The following is a description of a gene set: from publication Yevshin I, Sharipov R, Kolmykov S, Kondrakhin Y, Kolpakov F (PMID 30445619) species: Mus musculus Mouse Gene Set: ARID4B_TARGET_GENES, and this is the list of marker genes: Trit1, Kdm4d (NCBI Gene Id 244694), Tmsb10, Mfsd11, Armc7, Vac14, Emc8, Eno3, Pard3b, Mettl3 (methyltransferase 3, N6-adenosine-methyltransferase complex catalytic subunit), Tbl1xr1 (transducin (beta)-like 1X-linked receptor 1), Smoc1, Rpl3, Tlk2 (NCBI Gene Id 71049), Cdk12, Wdr53, Vamp2, Mrpl14, Nln, Stk11, C2, Fbxo21, Resf1, Nup35, Dpm1, Rab10os, Gm36527, Eif2b3, Enkd1, Zfp799, Rpl5, Nufip2, Dusp1, Fbxl7, Gm20716, Spata6, Ints7, Hivep1, Vps37a, Dhrs1, Pnpla7, Epc1, Tbcc, Zgrf1, Rpl35a (ribosomal protein L35A), Selenos, Cisd3, Zfp839, 1810012K16Rik, H2ac5-ps, Mafa, Plec, Gkap1, Stx18, Tcf7l2, Spcs3, Tmem64, Eif3j1 (NCBI Gene Id 98779), Mrpl13, Ywhae, Cbfa2t2, Galnt16, Tsr1, Coq8a, Raly, Cacng2, Ets2, Nhlrc3, A430018G15Rik, Adk, Gm29417, Gpx4, B4galt7, Ddx39b, Zfp689, Gm16675, Whrn, Dtd2, Malsu1, Cnot6l, Ppdpf, 2010320M18Rik, H1f0, Cirbp, Polh, Med15, Pax2, Syde2, Cryzl1, Tsc22d1, Ifngr1, H3c3, Gm22589, Tex14, Suv39h2, Arl8a, AI506816, Zbtb37, Comtd1, Zc3h6, Usp14, Ndufv1, Hic1, Zbtb46, Lemd3, Dpf1, Utp20, Txndc11, Nol10, Tigd2, Med12l, Set, Atp5mc3, Rasa3, Gm20033, Ssbp3, Cerk, Thra, Taco1, Tmem234, Tug1, Apex1, Eif4a1, Fhdc1, Rrbp1, Gm10658, Gm26224, Eif3i, Gm12743 (NCBI Gene Id 115489936), 1810062O18Rik, Tcf7 (transcription factor 7, T cell specific), Mrps7, Nle1, Diaph3, 1700027A07Rik, Zkscan1, Mrps17, 4930515G01Rik, 2810408I11Rik, Pitpnm2, Eif5, Kmt5a, Septin11, Gm15853, Saxo2, 2810025M15Rik, 4933405L10Rik, Tet3, Chrna3, Ybx1, Socs2 (suppressor of cytokine signaling 2), 6330403L08Rik, Iqch, Ei24, Luc7l (Luc7-like), Hnrnpk, 4930505N22Rik, Dok2, Il6st, D430041D05Rik, Bbc3, Phf20, Prr14 (NCBI Gene Id 260374), Crat, Lcorl, Lrfn4, Gpbp1l1, Gm11973, Gm24000, Cdkn2a, Mrps2, Hnrnpdl, Rai1, Paip2, Mast4, Slc25a13, Rbm33, Rora, Tdrd3, Irs2, Trip12, Syncrip, Tns1, Ncoa2, Rnf169, Tnk2, Mxi1, Nbea, Papola, Ankrd9, Bok, Rad51c, Mapk3, Kbtbd8, Sike1 (suppressor of IKBKE 1), Cyp27a1, 9330151L19Rik, Smim10l1, Kcnd3, H2bc3, Gba2, Ebf3 (early B cell factor 3), Ascc3, 2810013P06Rik, Rnf170, Pias3, Arf3, Rc3h2, Tnip1, Dnaaf5, Cdan1, Impa1, Ctcf, Zswim7, Ulk2, Vps13b, Zfp629, Wdfy3, Akap10, Chmp6, Adora2b, Fars2, Plekho1, B230319C09Rik, Gm29707, Aimp1, 4930449I04Rik, Cdh1, Sinhcaf, Kdm3a, Surf4, Gm2a, Zfp507, Gm22357, Rpl21, Stat5a, Hexd, Ankra2, Irf2, Sp3os, Sacm1l, Ston2, Snta1 (syntrophin, acidic 1), Vrk2, Lsm2, Cxxc5 (CXXC finger 5), Rexo1, Dop1a, Nisch, Gm5602, Pbx3, 2500004C02Rik, Dnajc11, Ube2d1, Naf1, Efl1, Atp5pf, 4930535L15Rik (NCBI Gene Id 78027), Clic4, Rpl18a, Plch2, Gm5468, Gm9967, a (NCBI Gene Id 50518), Gm11772, Prcd, Gar1, 1700096K18Rik, Ahcyl1, Pomgnt1, Rpl32, Ankmy2, Txndc5, Kifc1, Ss18l1, Htra3, Sntb2, Zyg11b, Cdc14b, Tia1, N4bp2os, Rbm39, Dhx15, Frmd4b, Sox5, Mybl2 (NCBI Gene Id 17865), Snapin, Haus8, Tex10, Cfap43, Znrf1, Mtbp, Id3, Ddx21, Plekhj1, Soat1, Hnrnpr, Kntc1, Kmt2a, Tbck, 9230114K14Rik, Fam83f, Elk4, H13, Sp3, Cul1, 4933406C10Rik, Lrpprc, Ccna2, Mir5627, Cspg5, Zfp207, Arih1 (NCBI Gene Id 23806), Rgs7, Snord43, Nr1h2, Rnf214, Usf2 (upstream transcription factor 2), Safb2, Lypla2, Jarid2, Atp8b2, Espl1, Srp9, Usf1, Cggbp1, Kansl1l, Eif4a2, Ran, E2f5, Ypel3, Zfp36, Naa30, Cenpf, Ints2, Ajap1, Aebp2, 9430037G07Rik, Ppp1r9a, Polr2m, Mrpl41, Pltp, Pbrm1, Cebpa, Rpl11, Zfc3h1, Pspc1, Pstpip2, Ubp1, Mgme1, Duxf1, Snx24, Gmnn (geminin), AA386476, Bltp2, Gm20753, Cops9 (NCBI Gene Id 66915), Sys1, Rab32, Ganab (alpha glucosidase 2 alpha neutral subunit), Morc2a, Gm15420, Cdc20, H1f10, Arid2, Mir7045, Ago1, Steap1, Ung, Erap1, Ahdc1, Tanc1, Tmem44, Rps17, Wdr26, Sptbn1, Akap1, Hyal2, Agap3, Ercc8, Elmo1, Rad51, Qrich1, Inppl1, Gas5, Unkl, Sik2, Zfp668, Srrt, 4931440P22Rik, Gm27017, Arid3a, Ufm1, Cnot7, Slc25a46, Snai1, Spice1, Ikbip, Ap3m1, Slmap, Pfdn4 (prefoldin 4, NCBI Gene Id 76717), Cep55, Bcl7c, Ehmt2, Kcnd3os, Sf3a2, Stkld1, Eif4g2, Gorab, Proser1, Ing2, Gse1, Cox4i1, Gm22748, Gpr83, Shcbp1 (NCBI Gene Id 20419), Dynlrb1, Prkar1b, Vcpkmt, Magi3, Nsun2, Klc1, C230096K16Rik, N4bp2, Pten (NCBI Gene Id 70161), Hdhd5, Cacna1h, Cnep1r1, Gm16892, Hmga1, Fbxl17, Gm6277, Bmpr2, Crem, Rnf19b (NCBI Gene Id 75267), A430057M04Rik, Eci1, Zfp697, Eaf2, Atg4b, Tubd1, Pdgfa, Pts, Srsf10, Hectd1, E2f7, 1700084E18Rik, Atp6v1g2, Psmf1, Hs6st3, Brd2, Cdc42, Ccnyl1, Msh2, Taf6l, Limd1, 4930426L09Rik, Exo1, Rgp1, Ccl25, Mtcl1, Srsf2, Rasal2, Myc, Pde7a, Snx5, AI480526, Vps52, Ppp1r9b, Shld2, Lsm14a, Ep300, Maml1, Lamtor2, Hp1bp3, Clba1, Rmi1, Strn4, Sugp2, E130102H24Rik, Foxq1, Chka, Taf4, Gins1, Ggps1 (NCBI Gene Id 97873), Memo1, Gm10501, Foxred1, Unc119, Pnrc1, Gnas, Slc38a2, Mal2, Csnk1d, Hmgb1, Gga3 (golgi associated, gamma adaptin ear containing, ARF binding protein 3), Cdk6, Pxn, Emc3, Fbxo5 (F-box protein 5), Setd2, Abca3, Fbxo36, Bach2, Ptov1, Klc2, Unc5c, Cdkn2c, Gm9917, Creb3, Rrp7a, Rplp0 (NCBI Gene Id 64336), Bahcc1, Tgfbr1, Elp5 (NCBI Gene Id 54351), Rreb1, Hsp90aa1, Gabpb1, Rpl24, Dsel, Cic, Nfic, Eif4g3, Cramp1, Rps14, Ctsa, Rad18, Ubqln1, Acp6, AY074887, Uhmk1, Cables1, Ptpa, Gm10961, Afg1l, Tprg1l, 1110025M09Rik, Mocs3, Cdk8 (NCBI Gene Id 264064), Polr1e, Crlf3, Xkr8, Rara, Zic2, Gm13375, Ttc19, Cdkn1b (cyclin dependent kinase inhibitor 1B), Epha2, E2f3, Fbxw7, Edc3, 1700086P04Rik, Cst3, Ppib, Gm22489, Hoxd8, Farsa, Klhl7, C1qbp, Midn, Rnf103 (ring finger protein 103), Slc10a7, Gtdc1, Tax1bp1, Kdm1a (lysine (K)-specific demethylase 1A), I830134H01Rik, Ltv1, Mbd6, Ift140, Osgep, Mtrex, Azin1, Patz1 (POZ (BTB) and AT hook containing zinc finger 1), Neo1, Cnppd1, Adamts3, Zfp593, Klf13, Cpeb3, Adpgk, Pprc1, Bfar, Sypl1, Sphk1, Atp2a2, Znhit3, Mroh8, Kbtbd8os, Abcc1, Rps18, Pakap, Agbl3, N4bp2l1, Sdk2, Prkce, Snora7a, Zbtb25, Efcc1, Tent4a, Dscaml1, Ints15 (integrator complex subunit 15), Tmem128 (transmembrane protein 128), Zfp280d, Ube2j1, Ttc39d, Tpd52l2, Utp14b, Gm26676, Glud1, Cpeb2, Larp7, Rap1gds1, Meiob, Cnnm3, Tsen54, Cdc73, Trnt1, Mboat1, Arid4b, 1600012H06Rik, Espn, Atp10a, 1810021B22Rik, Thap7, Ankrd16, Eif5a, 4930478K11Rik (RIKEN cDNA 4930478K11 gene), Plxnb1, Slc2a8, Psma4, D330023K18Rik, Atg4c, Nr2f6, Hexim2, Qki, Zfp523, Ncoa1, Helz, Poglut1, Srpra, Mir8109, Zmiz2 (zinc finger, MIZ-type containing 2), Tal1, Arhgap42, Lpin2, 1600020E01Rik, Med13l, Sgtb, Prdx1, Gm11423, Ccz1, Sdc4, Pcid2, Pax5 (paired box 5), Ncapg2, 1700125G22Rik (RIKEN cDNA 1700125G22 gene), Fez2, Dlg5, Brpf3, Atp9b, Pcbp1, Tmtc1, Dyrk2, Klf3, Pms2, 1700112D23Rik, Arid1a, Fancd2, Vapa, Slc11a2, Zfp105, Kat6b, Taf10, Igf2bp2, 1700052K11Rik, Ppp3ca, Dhps, Igf2bp3, Nfatc1, Srcap, Tshz2, Fbln1, Gm27003, Rsl24d1, Ago2, Zbtb1, Arid1b, Enoph1, Ccnb1, Zfp646, Amfr, Adck5, Gps1, Wdr4, 1700120B22Rik, Csrnp2, Exosc3, Mir762, Polr3e, Miga2, Hdgf, Pcyox1, Samd4, Mterf3, Eeig1, Wrap53, Pds5a, Gm7160, Thap2, Tfdp1, Nr6a1, Gm10069, Aco2, Trib1, Rcor1, Yes1, Gan, Rpn2, Gm5475, Mir1900, Iqcg, Trmt61a, Phlda1, Pum2, Snx10, Armc6, Golm1, Arhgap21, Rasgrf2, Utp15, Gm10687, Ptpre, Npc1, Phf5a, Cog7, Unc119b, Apaf1, Pgap3, Kctd12, Smc3, Kcmf1, Acin1, Prrc2a, E530011L22Rik, Kif18b, Kpna2, Tedc1, 4930404I05Rik, Wtap, Myo9b, Endov, Nit2, Dab2ip, Kpna4, Vangl2, Tiparp, Stk25, Aagab, Dna2, Pex2, Srd5a3, Idh3a, Psmb3, Agbl5 (ATP/GTP binding protein-like 5), Ppt2, Rad9b, Fbxl5, Ilkap, Gm5577, Slc25a38, Ece1, Ssx2ip, Mtus2, Gm38158, Basp1, Ubtf, Afap1l2, Dync1i2, Fzd7, Xpnpep1, Fkbp4, Gdnf, Gm10638, Setd1b, Rps10, Litaf, 4931406C07Rik